The following is a description of a gene set: Human Gene Set: REACTOME_BINDING_OF_TCF_LEF_CTNNB1_TO_TARGET_GENE_PROMOTERS studied in species Homo sapiens Binding of TCF/LEF:CTNNB1 to target gene promoters, and this is the list of marker genes: TCF7L1, MYC, RUNX3, TCF7, TCF7L2, CTNNB1, LEF1, AXIN2